Given this list of marker genes MYLK2, EEF2K, CAMK1G, MKNK2, CAMK2B, MYLK3, MKNK1, ELP3, PHKA1, CAMK1D, PTK2B, PRKAG2, CAMK4, CAMK1, MAPKAPK3, CAMK2G, ITPKA, CAMK2D, CAMKV, CAMKK2, PHKG2, PHKG1, PNCK, PHKA2, DAPK1, ELP4, CAMKK1, MAPKAPK2, CAMK2A, MAPKAPK5, here is a description of the gene set: species: Homo sapiens Human Gene Set: GOMF_CALCIUM_CALMODULIN_DEPENDENT_PROTEIN_KINASE_ACTIVITY Calmodulin-dependent catalysis of the reactions: ATP + a protein serine = ADP + protein serine phosphate; and ATP + a protein threonine = ADP + protein threonine phosphate. This activity require the presence of calcium-bound calmodulin.